The following is a description of a gene set: species: Mus musculus Mouse Gene Set: GOBP_CLUSTERING_OF_VOLTAGE_GATED_SODIUM_CHANNELS The process in which voltage-gated sodium channels become localized together in high densities. In animals, nodes of Ranvier differ dramatically from internodal axonal regions in very high densities of voltage-dependent sodium (Nav) channels responsible for the rapid, inward ionic currents that produce membrane depolarization., and this is the list of marker genes: Nfasc, Sptbn4 (spectrin beta, non-erythrocytic 4), Ank3, Gldn, Nrcam, Myoc, Sclt1